The following is a description of a gene set: Human Gene Set: GOBP_RNA_5_END_PROCESSING studied in species Homo sapiens Any process involved in forming the mature 5' end of an RNA molecule., and this is the list of marker genes: RAMACL, NOP14, CMTR1, RPP25, RPP25L, SNRPF, RPP30, RNMT, TRMT10C, POP7, SNRPG, TBL3, POP1, NCBP1, SNRPD2, NOP9, NCBP3, ABT1, THG1L, PNPT1, RAMAC, SNRPB, UTP20, RPP21, SNRPE, CMTR2, RPP14, HSD17B10, TGS1, RNGTT, SNRPD3, RPP40, SSB, POP4, SNRPD1, POP5, PRORP, RPP38